The following is a description of a gene set: Mouse Gene Set: GOBP_OOCYTE_CONSTRUCTION studied in species Mus musculus The synthesis, deposition, and organization of the materials in a cell of an ovary; where the cell can then undergo meiosis and form an ovum. An example of this is found in Drosophila melanogaster., and this is the list of marker genes: Pld6, Wdr77, Tdrd5, Tdrkh, Tdrd1 (NCBI Gene Id 83561), Tdrd7, Tdrd6